The following is a description of a gene set: Human Gene Set: HP_LEUKODYSTROPHY studied in species Homo sapiens Leukodystrophy Leukodystrophy refers to deterioration of white matter of the brain resulting from degeneration of myelin sheaths in the CNS. Their basic defect is directly related to the synthesis and maintenance of myelin membranes. Symmetric white matter involvement at MRI is a typical finding in patients with leukodystrophies., and this is the list of marker genes: NDUFS1, FBP2, NDUFAF1, FBXL4, TMEM106B, NDUFS4, SPTBN1, SLC35B2, ADAR, NDUFAF3, TIMMDC1, ABAT, POLR1A, ARSA, POLR1C, ISCA2 (iron-sulfur cluster assembly 2), EDNRB, NDUFS7, COA8, COX6B1, GTPBP3, GJC2, IBA57, NDUFV1, AIMP2, SP110, NDUFA11, ERCC6, NOTCH2NLC, NADK2, HYCC1, NDUFAF2 (NADH:ubiquinone oxidoreductase complex assembly factor 2), ISCA1, PEX10, NDUFAF4, FA2H, NDUFV2, RNASEH2C, RNU7-1, TAOK1, TREX1, POLR3A, NKX6-2, NDUFS8, TUBB4A, PC, NUBPL, BOLA3, MT-ND1, NDUFS6, GLRX5, DARS2, MT-ND2, SNORD118, NDUFA1, ATP11A, TMEM126B, HIKESHI, PYCR2, NDUFAF5, SAMHD1, REPS1, ALG8, PLEKHG2, POLR3B, TMEM63A, NDUFB10, PEX1, IFIH1, LIAS, PSAP, AIMP1, MT-ND3, NDUFB9, NDUFB3, HSPD1, PI4KA, NDUFS2, RARS1, RNASEH2B, EXOSC5, EPRS1, KARS1, DAG1, ACER3, PNPT1, ACOX1, TUFM, SLC16A2, NDUFS3, PLP1, FOXRED1, PEX16, SOX10 (SRY-box transcription factor 10), LSM11, NDUFA6, NDUFAF8, RNASEH2A, SDHB, NDUFB11, CTC1